The following is a description of a gene set: part of: Glycerophospholipid biosynthesis; PI Metabolism Reactome Pathway: PI and PC transport between ER and Golgi membranes The phosphatidylinositol transfer protein beta isoform (PITPNB) bound to phosphatidylinositol (PI) complex transports from the endoplasmic reticulum (ER) membrane to the Golgi membrane, where phosphatidylcholine (PC) is exchanged for PI. PITPNB now in complex with PC transports back to the ER membrane where PI is now exchanged for PC, and the cycle repeats. This process has been characterized in detail in bovine and rodent model systems (e.g., Wirtz et al. 2006; Ghosh and Bankaitis 2011), which provide a framework for organizing the more limited data available for the very well conserved human proteins and processes( Carvou et al. 2010, Shadan et al. 2008). studied in species Homo sapiens, and this is the list of marker genes: PITPNB